The following is a description of a gene set: species: Homo sapiens Human Gene Set: GSE43863_TFH_VS_LY6C_INT_CXCR5POS_EFFECTOR_CD4_TCELL_UP from publication Hale JS, Youngblood B, Latner DR, Mohammed AU, Ye L, Akondy RS, Wu T, Iyer SS, Ahmed R (PMID 23583644) CD4 T follicular helper (Tfh) cells provide the required signals to B cells for germinal center reactions that are necessary for longlived antibody responses. However, it remains unclear whether there are CD4+ memory T cells committed to the Tfh lineage after antigen clearance. Using adoptive transfer of antigen-specific memory CD4+ subpopulations (based on CXCR5 and Ly6c expression)in the LCMV infection model, we found that there are distinct memory CD4+ T cell populations with commitment to the Tfh and Th1 lineages. Our conclusions are based on gene expression profiles, epigenetic studies and phenotypic and functional analysis. The gene expression profiles of virus-specific CD4 T cell subets at effector and memory stages is presented here. Genes up-regulated in CD4 SMARTA effector T cells during acute infection of LCMV: follicular helper (Tfh) versus Ly6c int CXCR5+., and this is the list of marker genes: RBM8A, SLC20A1, ITLN1, PPARG (NCBI Gene Id 5468), PPRC1, EIF1, IFNG, AFF1, MATN1, ARHGDIG, GJB3, SRSF6, ADAM10, POLE4, GPR182, TIMM8A, WSB2, PIGR, PDXK, LRRC59, BCL7C (BAF chromatin remodeling complex subunit BCL7C), UTP4 (UTP4 small subunit processome component), PHOX2A, ENY2, NHP2, GRWD1, IL1R2, RRAD, MYO5B, METAP1, CACNA2D1, CPQ, SURF6, PLSCR1, ZFAND5, GDF11, CXCR4, MAFG, LRP2, EXOSC10, SRGN, EPHA2, A2M, IRS2, CDKN1C, ST6GALNAC4, RPP14, REN, CSNK1D, RRP12, PPP1R7, SFT2D1, GNAI3, RRP9 (ribosomal RNA processing 9, U3 small nucleolar RNA binding protein), BAD, UBFD1, PHF5A, UBR7, RCL1, SNRPB2, FARSA, ACOT9, CLCNKB, IDI1, NUP62, ERCC2, IL4I1, POLB, SOX18, DGAT1, SLC31A1, CAMK4, RNF138, SERTAD1, DNAJA1, SPRED2, LARP7, ETS2, ZNF622, MED20, IMP4, BLK (NCBI Gene Id 84743), GTF2H1, LITAF, SAR1A, WDR26, ROR2, C19orf48P, RABGGTB, BTG1, STIP1, STAT6, PUS1, WDR55, RNF2, PDRG1, NPM1, BRAF, PTPN20, PRELID3B, UBXN4, TUFT1, EEF1A2, DUSP2, SPP1, POLR2L, C1GALT1C1, TMEM165, GNPTAB, CDON, GDNF, FOXN2, ZSCAN21, NSUN2, SNRPA, SOX2, MACIR, SCPEP1, SPTBN2, ERH, SEMA6B, ARF3, NOP56, HSPD1 (NCBI Gene Id 56733), SLC1A2, CDK5R1, ATE1, CRABP1, DDIT3, HCRT, SURF2, TPP1, NCK2, EGLN2, PAX8, NIFK, SEMA4F, PYCR3, WAC, EIF3D, ADRA2C, NFE2L2, PRPF38A, IL1R1, MEPCE, SLC7A6, TOR1AIP2, KCNJ11, DDRGK1, CH25H, AARS1, ZFP36, CSTB, RSL1D1, DDX46, ARF1, SIAH2, POLR2H, MARCKSL1, NASP, PLPBP, POR (cytochrome p450 oxidoreductase), HNRNPA2B1, RELL1, WDR5, MCAM, JMJD6, SLC39A6, NDUFAF4, GOSR1, CCR7, ASTN1, HK2, DOHH, CTSV, C1QTNF1, KRAS, OSBPL1A, SIDT2, BYSL, AGO2, CTNNBIP1, KANSL2, WDR75, PRDX1, DCTPP1, TOMM40, ATP6V0D1, SH2D2A, IER2, NMT2, LYSMD2, RCN1, TXLNG, AVPR1A, LCK, RNF4, SYNPO, RRAGC, USP10